Given this list of marker genes PIWIL2, MIEN1, TMEM39A, SMC2, SNRPG, SLC25A47, KCNN4, ATPAF2, ERBB3, INTS3, TSR3, IMP3, EI24, LMNB1, ERAP1, GLO1, CHADL, CIAO2B, TMEM101, PAPOLA, CCL22, LAT, GNPTAB, FAM216A, NT5M, NELFB, NAB2, BLZF1, GCLM, HBEGF, AP4S1, PLOD2, SYNJ2BP, EIF2B5, BIK, CTTN, RRP7A, BTF3L4, TNFSF9, NUDCD2, MKRN3, OCIAD1, TMEM183A, IGF2R, EIF3I, PDHA2, ADPRH (NCBI Gene Id 141), GUCA1B, WRAP73, TPRN, NOL6, BLOC1S3, IL1R2, MRPL41, GPA33, B3GNT3, THNSL1, IER5, CHID1, FANCC, ARL6IP4, TEX261, METTL22, STAR, ELMO3, SRP54, DFFB, AIP, BABAM1, WDR83OS, GLMN, EGFL7 (EGF like domain multiple 7), IRF2BP1, TAF13, HTT, MRPL49, PYCR1, ST7, CDSN, ZPR1 (NCBI Gene Id 95155, ZPR1 zinc finger), SNRPC, PSMD13, STX18, C3orf38, RPP25L, DTD1, SCFD1, CYP11A1, CHPF, TEF, YAE1 (YAE1 maturation factor of ABCE1), C1QL3, CCDC43, ADGRG1, DDB1, DNAAF5 (NCBI Gene Id 54919), U2AF1, SLC25A4, ZIM3, APOE, TMEM126A, TOMM40L, TXNRD2, MED28, RTN4IP1, B3GNT2, SLC25A13, COMMD9, REXO4, BLMH, GKN2, AHCYL1, SCYL1, ACSBG1, UFC1, OTUD6B, PAGR1, TMEM216, SAR1A, LBH, TRIP4, PARS2, IL15RA, COPS2, HIF3A, RPS2, WIZ, METRN, SLC31A1, PRPF40B, CCL17, BET1, GLRX3, GPX1, C1QTNF12, HEMK1, C8orf82, CPOX, SNX19, SDCBP2, MRPL28, BAP1, SNRNP25, RCAN1, PTPN11, SMG8, SH3BP2, EGR4, UNG, HGFAC, NUP62, SPAG1, HDLBP, TUFT1, ID1, HS6ST3, TTC8, COQ5, NAA35, DLST, UBXN10, IFNG, MED11, CDC26, SOD2, WBP4, NR2F6, HAL, ARHGAP35, SYP, DDIT4, MTIF2, HIC1, CCDC115, TMEM158, POFUT2, DYRK3 (dual specificity tyrosine phosphorylation regulated kinase 3), VAPA, ABHD17A, NAA20, POP5, HM13, C9orf40, NDUFA10, NFATC1, CDKN2A, METTL3, MRPS23, UBE3C, AOC3, ERI3, ZNF426, GOLGA7, LRP4, NAA15, HSPA8, PLK3, ETFA, LCP1, NMD3, here is a description of the gene set: Human Gene Set: GSE12198_CTRL_VS_LOW_IL2_STIM_NK_CELL_DN Genes down-regulated in NK cells: primary versus stimulated by low dose of IL2. from publication Fujisaki H, Kakuda H, Shimasaki N, Imai C, Ma J, Lockey T, Eldridge P, Leung WH, Campana D (PMID 19383914) Transcriptional profiling of NKAES-derived NK cells after 7 days of culture compared to primary human NK cells and NK cells stimulated by low or high dose IL2 after 7 days of culture. species: Homo sapiens